Given this list of marker genes MUC1, TXN, LGALS3 (galectin 3), RERG, FLNA, FBLN5, ILK, EZR, PGK1, CALR, CLU, NDRG1, FKBP5, PTEN, WNT3, RAN, PARK7, SELENBP1, MIF, PHB1, AGR2, LGALS1, HSPA6, KPNB1, CTNNB1, WNT3A, PIM1, AZGP1, here is a description of the gene set: from publication Hwang SI, Thumar J, Lundgren DH, Rezaul K, Mayya V, Wu L, Eng J, Wright ME, Han DK (PMID 16799640) Human Gene Set: HWANG_PROSTATE_CANCER_MARKERS Proteins implicated in prostate carcinogenesis. species: Homo sapiens Successful treatment of multiple cancer types requires early detection and identification of reliable biomarkers present in specific cancer tissues. To test the feasibility of identifying proteins from archival cancer tissues, we have developed a methodology, termed direct tissue proteomics (DTP), which can be used to identify proteins directly from formalin-fixed paraffin-embedded prostate cancer tissue samples. Using minute prostate biopsy sections, we demonstrate the identification of 428 prostate-expressed proteins using the shotgun method. Because the DTP method is not quantitative, we employed the absolute quantification method and demonstrate picogram level quantification of prostate-specific antigen. In depth bioinformatics analysis of these expressed proteins affords the categorization of metabolic pathways that may be important for distinct stages of prostate carcinogenesis. Furthermore, we validate Wnt-3 as an upregulated protein in cancerous prostate cells by immunohistochemistry. We propose that this general strategy provides a roadmap for successful identification of critical molecular targets of multiple cancer types.